Given this list of marker genes NF2, POGLUT1, NF1, PSENEN, POFUT1, SPRED1, KRT5, here is a description of the gene set: The presence in the inguinal region (groin) of an increased number of freckles, small circular spots on the skin that are darker than the surrounding skin because of deposits of melanin. Inguinal freckling Human Gene Set: HP_INGUINAL_FRECKLING studied in species Homo sapiens